Given this list of marker genes Elf3, Notch3, here is a description of the gene set: This event has been computationally inferred from an event that has been demonstrated in another species.<p>The inference is based on the homology mapping from PANTHER. Briefly, reactions for which all involved PhysicalEntities (in input, output and catalyst) have a mapped orthologue/paralogue (for complexes at least 75% of components must have a mapping) are inferred to the other species. studied in species Mus musculus part of: Signaling by NOTCH Reactome Pathway: Pre-NOTCH Expression and Processing electronically inferred by orthology from the curated human pathway